Given this list of marker genes JUP, WNT7A, KCNH1, CRKL, COL7A1, MAPK1 (NCBI Gene Id 5594), KCNN3, ARID1A (AT-rich interaction domain 1A), BCR, LRP4, KRT14, ATP6V1B2, DSP (desmoplakin), APC, PIGF, PORCN, NOTCH1, ERI1, GPC4, here is a description of the gene set: species: Homo sapiens Human Gene Set: HP_ABSENT_TOENAIL Absent toenail Congenital absence of the toenail.